Given this list of marker genes BZW1, HRCT1, VPS53, ZBTB7B, KNSTRN, EIPR1, SIM2, SNCAIP (NCBI Gene Id 9627), HSPA9, SYN2, STX17, AASS, SAR1B, AGO4, MOGS, POLR3G (RNA polymerase III subunit G), HIF1AN, UBQLN1, PROP1, CRAMP1, MAN1C1, CCDC22, SNX8, SPNS2, IRF1, RNF168, EIF4G3, TUB, IFI27, PLEKHG1, GPBP1, TMEM44, PLAAT1, SLC26A5, PTPN11, DCDC2C, SLC18A1, ATRX, FKBP1A, ETF1, ZNF18, GUCY1B1, here is a description of the gene set: Human Gene Set: MIR6802_3P species: Homo sapiens Genes predicted to be targets of miRBase v22 microRNA hsa-miR-6802-3p in miRDB v6.0 with MirTarget v4 prediction scores > 80 (high confidence targets). from publication Chen Y, Wang X (PMID 31504780)